The following is a description of a gene set: Human Gene Set: WANG_THOC1_TARGETS_DN Genes down-regulated in testis tissue expressing hypomorphic allele of THOC1. from publication Wang X, Chinnam M, Wang J, Wang Y, Zhang X, Marcon E, Moens P, Goodrich DW (PMID 19307311) Accumulating evidence suggests that regulation of RNA processing through an RNP-driven mechanism is important for coordinated gene expression. This hypothesis predicts that defects in RNP biogenesis will adversely affect the elaboration of specific gene expression programs. To explore the role of RNP biogenesis on mammalian development, we have characterized the phenotype of mice hypomorphic for Thoc1. Thoc1 encodes an essential component of the evolutionarily conserved TREX complex. TREX accompanies the elongating RNA polymerase II and facilitates RNP assembly and recruitment of RNA processing factors. Hypomorphic Thoc1 mice are viable despite significantly reduced Thoc1 expression in the tissues examined. While most tissues of Thoc1-deficient mice appear to develop and function normally, gametogenesis is severely compromised. Male infertility is associated with a loss in spermatocyte viability and abnormal endocrine signaling. We suggest that loss of spermatocyte viability is a consequence of defects in the expression of genes required for normal differentiation of cell types within the testes. A number of the genes affected appear to be direct targets for regulation by Thoc1. These findings support the notion that Thoc1-mediated RNP assembly contributes to the coordinated expression of genes necessary for normal differentiation and development in vivo. species: Homo sapiens, and this is the list of marker genes: VDR, INHBB, NOTCH1, GATA1, GATA4, CTSL (cathepsin L), AMHR2, NR5A1, WT1, SOX9, KIT, CLDN11 (claudin 11), MAGEA4, NR0B1, TESMIN, GDNF, SOX8, PPT1, CLU, DHH